Given this list of marker genes RBPMS-AS1, TMEM132C, ANG, GLUL, HADH, PRDM16-DT, NWD2, RORB, RGS17, ALDH6A1, GLIS1, MOCS1, GINS3, FAM240C, ZBTB7C, RORB-AS1, AZGP1, TRIM55, NDRG4, ERBB3, CPAMD8, CFAP74, MAPK8IP3-AS1, BMP3, RTN1, GSDMB, CECR2, SCEL, LINC01612, NTSR2, ALPK3, GPAT3, ALK, SLC2A4, CIDEA, GJC3, ADSS1, C6, SC5D (NCBI Gene Id 6309), PGM5-AS1, ORMDL3, ADH1B, LINC02636 (NCBI Gene Id 102723350), PRIMA1, SLC19A3, ALDH1L1-AS2, ACVR1C, SCN7A, PDK2, DAPK2, COQ8A, STOX1, EIF4EBP1, ANKRD53, SPX, C1QTNF7-AS1, GPD1L, RASSF6, RASL10B, SLC27A2, NAALAD2, TMEM52, COL9A1, PLIN5, PGM5P4-AS1, here is a description of the gene set: from publication Konigorski S, Janke J, Patone G, Bergmann MM, Lippert C, Hübner N, Kaaks R, Boeing H, Pischon T (PMID 35953519) Many studies have shown that abdominal adiposity is more strongly related to health risks than peripheral adiposity. However, the underlying pathways are still poorly understood. In this cross-sectional study using data from RNA-sequencing experiments and whole-body MRI scans of 200 participants in the EPIC-Potsdam cohort, our aim was to identify novel genes whose gene expression in subcutaneous adipose tissue has an effect on body fat mass (BFM) and body fat distribution (BFD). The analysis identified genes associated with adiposity, of which 531 encode a known protein and 487 are novel candidate genes for obesity. Enrichment analyses indicated that BFM-associated genes were characterized by their higher than expected involvement in cellular, regulatory and immune system processes, and BFD-associated genes by their involvement in cellular, metabolic, and regulatory processes. Mendelian Randomization analyses suggested that the gene expression of genes was causally related to BFM and BFD. Six genes were replicated in UK Biobank. Genes that exhibit a negative CJAMP (Copula-based joint analysis of multiple phenotypes) beta estimate (beta < 0) for association with subcutaneous adipose tissue mass. Human Gene Set: KONIGORSKI_INCREASED_SUBCUTANEOUS_ADIPOSE_TISSUE_MASS_DN studied in species Homo sapiens